Given this list of marker genes Cd74, Cd163, Rac2, Cd86, Cd68, Lyz2, Cd52, Cd83, Cd14, F3, here is a description of the gene set: Macrophage markers Mouse Gene Set: WP_MACROPHAGE_MARKERS studied in species Mus musculus